Given this list of marker genes Dnajc19, Gata3, Ndufs1, Ubxn4, Lmbr1, Prkcb, Cbll1, Lman1, Med17, Ednra, Max, Sgpp2, Zfp354a, Rab5c, Pde1c, Wfdc12, Six6, Sgms1, Avpr1b, Apc, Zcchc2, Fkbp5, Cdo1, Unk, Zfp26, Shld2, Nherf4, Ptprk, Atp6v1a, Pde10a, Arpp19, Sepsecs, Rbm44, 4921524J17Rik, Golga7b, Gtf2b, Col27a1, Zfp503, Smad2, Rasa2, Cldn12, Kif23, Spp1, Prkcd, Arpc5l, Prpf4b (pre-mRNA processing factor 4B), Tmem108, Haus2, Slc16a10, Tmem30a, Slc16a9, Adarb1, Ugt8a, Cers6, Lhfpl2, Clspn, Fbxl17, Nmrk1, Ndrg4, Zxdb, Cxxc4, Taf4b, Polr3d, Vti1a, Clxn (NCBI Gene Id 74659), Nr3c2, Dnajc14, Zfp781b, Igsf9b, Olfm5, Dimt1, Ncoa1 (nuclear receptor coactivator 1), Get1, Tmem132b, Tmpo, Smco3, Grina, Rev1, Klhl14, Kat7, Cnot2, Col25a1, Cenpc1, Slc17a4, Six4, Tia1, Cpsf6, Daam1, Dennd1b, Iars2, Bcl6, Ubap2l, Crem, Ccdc169, Uty, Pon3, Chmp1b2, Skil, Onecut2, Apln, Mapk10, Aicda, Nexmif, Api5, Egr1, Ankrd1, Rfx6, Chek1, Osgep, Prkacb, Sox6, Qrfprl, Prdx6, B3gnt2, Plxnc1, Add3, Sp1, Nup58, Cdyl2, Ppp1r9b (NCBI Gene Id 217124), Syap1, Akap7, Nampt, Mei4, Riok3, Coa5, Spink5, Sval3, Klf15, Katnbl1, Csnk1g1, Fam76a, Pik3ca (NCBI Gene Id 70742), Commd2, Zfp715, Ctdspl2, Rab7, Ska2, Klf6, Stk25, Sall1 (NCBI Gene Id 58198), Casp8, Apool, Kdm6a, Rnf19b, Zmym5, Cnr1, Dsel, Kifc5b, Kif2a, Hmgb3 (high mobility group box 3), Tlnrd1, Kat6a, Npas2, Lrrc59 (NCBI Gene Id 98238), Itsn1, Sgk1, Dmxl1, Oip5, Dipk2a (NCBI Gene Id 68861), Aass, Npat, Cep97, Oas3, Srgap2, Bpnt2, Cxcl1, Btaf1, Dnaja1, Ap1g1, Ccdc166, Ccpg1, Ppip5k2, Bsn, Grem2, Itga2, Pwwp3b, Tas1r3, Lrrc2, Mc2r, Guf1, Clasp2, Cntn5, Btf3l4, Egr3, Jade1, AI182371, Slc4a7, Cmc2, Cenpi, Junb, Ccdc103, Pde4b, Eri1, Cdk5r1, Chpt1, Cfap52, Ube3a, Serpinb1a, Mosmo, Psd3, Qtrt2, Magi1, Vcpip1, Smco1, Nek4, Foxi1, Zfr, Dido1 (NCBI Gene Id 329580), Pou4f1, Rnf38, Trub1, Hook3, Trim44, Rc3h2, Cacul1, Phf20l1, Rfx8 (regulatory factor X 8), Lhx9, Slc5a7, Nhlrc1, Col17a1, Ccnt2, Smndc1, Cetn3, Epha5, Hs3st3b1, Tsc22d1, Zfand6, Foxc1, Ccdc87, Trhde, Cdh11, Ube2o, Arid3b, Rab27a, Klhl12, Mfsd2a, Camk2d, Dusp16, Smad5, Cstf2, Cdh2, Man1a2, Otulinl, Tpgs2, Lin28b (lin-28 homolog B), Lrba, Cldn8, Gabpb2, Fam217a, Pkd2, Nxpe3, Smoc2, Phip, Ralgps2, Pfkfb2, Cysltr1, Serpinb1b, Gramd1c (NCBI Gene Id 207798), Fam199x, Ptpre (NCBI Gene Id 19267), Irf2bp2, Jph1, Orai1, Slc17a1, Gad1, Dmrtc2, Adgrg2, Setbp1 (SET binding protein 1), Slc38a2, Lonrf1 (NCBI Gene Id 244421), Lypd1 (NCBI Gene Id 98472), Chd2, Mpp7, Fam91a1, Trim42, Smurf2, Itpripl2, Mtmr3, Cpeb4, Iws1 (NCBI Gene Id 73473), E2f6, Pi4k2a, Rufy2, Tmem26, Il13ra1, Cask, Clptm1l, Kalrn, Rassf1, Ddx17, Sema6a, Zfp446, Cox16, Acer3, Gpr143, Slain2, Lrrc58, Ptpn2, Ms4a4d, Tomm20, Ms4a4c, Ptgdr, Ano9, Ranbp6, Lemd3, Tmed5, Cdh7, Adam23, AI597479, Asxl2, Dnajc13, Map3k8, Lats1, Pspc1, Trp53bp1, Snx27, Sowahc, Zmat3, Plcl2, Gxylt1, Cts8, Rnf149, Esyt2, Birc6, Enox1, Upp2, Ssbp2, Phf8, Pou2f1 (POU domain, class 2, transcription factor 1), Rimklb, Csrnp3 (cysteine-serine-rich nuclear protein 3), Mis18a, Gjc1, Nxt2, Insm2, Pla2g4c, Nup155, Kbtbd2, Nectin3, Ttbk2, Spata13, Arhgap12, Pck1, Pdpk1, Nup35, Kcnip4, Erg, Pou6f2, Tyr, Smad4, Syt16, Cbfb, Gtse1, Arl14ep, Yes1, Rhoq, Cyrib, Kif1b, Mef2a, Golph3, Mrpl39, Lrat, Map3k4, Rnf44, Rbfox2, Me1, Ssh2, Zfp560, Myorg, Nusap1, Itpr1, Nras, Papolg, Pank3, Lmo4, Mcur1, Vmn1r65, Zfp1, Gch1, Pbrm1, Glrb, Macir, Frs2, Slc33a1, Khdc1b, Mtmr9 (NCBI Gene Id 210376), Pyroxd2 (NCBI Gene Id 74580), Zyg11b, Sirt1, Dnph1, Rnaseh2a, Ier3, Cmklr2, Fgfr2, Cd209a (NCBI Gene Id 170786), Gypa, Rnd3, Apobec3, Smim18, Krr1, Srpk2, Atoh1, Runx1, Vdac1, Enpp4, Etfbkmt, B3galt1, Kdsr, Homer1, Tigd5, Wdr43, Eea1, Gsk3b, Lrrtm2, Pes1, Rps6ka3, Kcne5, Itpr2, Nbeal1, Rasl11a, Tube1, Irgm2, Rora, Strbp, Srgap1, Tada1, Phlpp2, Brwd1, Tbcel, Fhad1, Ids, Stxbp2, Ccn4, Arl6ip6, Dennd4a, Jmjd4 (jumonji domain containing 4), Smc2 (structural maintenance of chromosomes 2), Septin11, Marchf5, Cd44, Ostm1, Zeb1, Aspm, Hlf, Zfp84, Wif1, Bclaf1, Dhx15 (NCBI Gene Id 13204), Creb1 (NCBI Gene Id 98624), Taok1, Golim4, Ltbp1, Msl2, Lurap1l, Crebrf, Ylpm1, Wtap, Eme1, Cfdp1, Cd300a, Intu, Cdk12, Rbm47, Chmp1b, Prlr, Vwa5a, Glo1, Gpr176, Shisa6, Hsd17b12, Psmc6, Jun (NCBI Gene Id 16476), Cltc, Zfp36l2, Ppil4, Fsd1l, Tmem196 (transmembrane protein 196), Tmprss11g, Elf4, Slfn4, Epb41l5, Dusp1, Tns3, Hecw2, Lhfpl4, Ms4a4b, Rasgrf2, Rbm41, Spn, Ahr, Nufip2, Nwd2, Gucy1b1, Cstf3, Zfp874b, Tgfbr1, Asxl1, Slc7a11, Dhx40, Dcaf10, Med14, Edem3, Secisbp2l, Slc38a1, Peak1, Mtx3, Ndnf, Or52n4, Rab1a, Psmb1, Pitpnb, Rnf152, Clic5, Unc5c, Gabrb3, Rbbp6, Adam21, Bcl11b, Plag1, B3galt2, Zmynd8, Cemip, Cramp1, Ccnb2, Spryd3, Ino80d (INO80 complex subunit D), Chic1, Abi2, Chrng, Ccdc82, Adam17, Carf, Mrc1, Tmem161b, Amer1, Eda2r, Ubap2, Agfg1, Gpr65, Bmt2, Rp1, here is a description of the gene set: Mouse Gene Set: MIR_466O_3P species: Mus musculus from publication Chen Y, Wang X (PMID 31504780) Genes predicted to be targets of miRBase v22 microRNA mmu_miR_466o_3p in miRDB v6.0 with MirTarget v4 prediction scores > 80 (high confidence targets).